The following is a description of a gene set: species: Homo sapiens Genes down-regulated in bone marrow-derived macrophages with IL6 knockout and 180 min of stimulation by: LPS versus IL10 and LPS. Human Gene Set: GSE5589_LPS_VS_LPS_AND_IL10_STIM_IL6_KO_MACROPHAGE_180MIN_DN IL-10 or IL-6 stimulation of control 129xC57BL/6 murine bone marrow derived macrophages in the presence of LPS. We used microarrays to detail the global programme of gene expression changes in response to IL-6 or IL-10 stimulation in the presence of lipopolysaccharide. BMDMs were isolated from control, IL-6-/-, and IL-10-/- mice on a 129XBL/6 mixed background mice and differentiated in the presence of CSF-1 for 6-7 days. Cells were scraped and plated in 6 well plates at 2x10e6/well. Cells were washed with complete DMEM and rested for 1-2 hr before stimulation with combinations of IL-10 (10 ng/ml), IL-6 (2 ng/ml) or LPS (100 ng/ml) for 45 min or 180 mins. Complete biological replicates were performed. from publication El Kasmi KC, Holst J, Coffre M, Mielke L, de Pauw A, Lhocine N, Smith AM, Rutschman R, Kaushal D, Shen Y, Suda T, Donnelly RP, Myers MG Jr, Alexander W, Vignali DA, Watowich SS, Ernst M, Hilton DJ, Murray PJ (PMID 17114459), and this is the list of marker genes: IGF2BP3, EIF3B, SUGT1, GYPC, HCFC2, LTA4H, DCP2, SMARCA5 (NCBI Gene Id 8467), RIPK1, AUH, ITGB7, PTPRS, AVEN, SYS1, RETSAT, SRSF3, PDE5A, KGD4, PECAM1, UBE2Q2, UBA1, CCDC127, SEMA4B, VWA8, PLPP1, RGCC, IPO4, ALAS1, PDHA1, DHX15, FEM1C, ETFB (NCBI Gene Id 2109), MMGT1, CINP (NCBI Gene Id 84716), NABP1, SLC7A11, ZYX, PIGK, HSDL2, CSRNP1, MET, NDUFS6, NIPA2, MRPL1, CLDN12, AIMP2, ITGB8, CARHSP1, VEZT, ACAA2, EEF1G, THRB, LYAR, TRIM29, NOL11, ATIC, CNST, GALNT1, PHGDH, SRGN, CCL25, FOCAD, SLAMF8, NOP14, RABGEF1, GPX4, DPY19L3, IFI30, HTR2B, ANGPTL3, PHOSPHO1, GAMT, RWDD1, HIPK2, DAP3, ANXA7, METTL16, MOB3B, TMEM248, PEX26, TTC9C, PMEPA1, LIN54, C1orf53, TM2D1, PLCB1, MMACHC (NCBI Gene Id 25974), NSMF, BMI1, MCRIP2, NUP93, HMGA1, RFK, PSPH, NDUFB6 (NCBI Gene Id 4712), MRPL51, PCMT1, KTI12, ATP5F1A, EIF3J, HMG20B, FPGT, FBL, GRAMD2B, HAT1, DCSTAMP, GLRX2, H2BC5, CSDE1, ACOT11, ANKRD40, F2R, PCYT1A, DUSP4, ARF6, SCFD2, STX6, TXNIP, EIF2S1, TOR2A, UMAD1, SCLY, SGTB, HIVEP2, ARL15, MYOF, MMP19, LYRM1, CDC34, TSFM, RAB38, TRIP12, DCUN1D1, NKAIN1, SLC22A4, SOAT2, PSMD2, SRC, THEM4, RGS1, TRMT6, CCR5, BAIAP2, SNN, ASNS, SERTAD2, TMED5, ENO1, ARL6IP5, RCBTB1, REM1, NDUFAF5, RPIA, CIITA, TGFBR3, B4GALT5, SH3TC1, SLC25A20, TMEM14A, CCDC88A, TMEM69, SNHG6, TMEM62, CCDC32, LTN1, TPP1, WDR12, CD274, PEX11G, NSUN2, GTF2F2, CCNYL1, SEPTIN7, PSMD4, TRMT61A, ARL14EP, HEBP1, PDE12, HDAC2, RIN2, OAT, SLC7A1, FMC1, PGAM5, SLC36A4, PRKAA1, NOP16, RNASEH2B, COPS5, PTK2, CDKN2B, MRTFB, ZNF330, ZSWIM1, BBLN, PRKCE, H3C4, QNG1, WRNIP1, SELENOM